The following is a description of a gene set: Reactome Pathway: Infection with Enterobacteria studied in species Homo sapiens Colonization of the gut with members of the Enterobacteriaceae family is unavoidable, as is the subsequent translocation to the urogenital tract. Infection is caused by strains with the ability to invade tissue, or when toxins are secreted. According to the WHO there are 4.5 billion cases of infection with enterobacteria every year, of which 1.9 million end in death, a number that would be much higher without antibiotics. Pneumonia and blood stream infections have the highest mortality. Gut bacteria translocate to and establish themselves in the airways by aspiration, hematogenous spread, or extension from adjacent infected structures, such as the sinuses or pleural space (W. Lee Hand & J. W. Smith, Immunology of Enterobacterial Infections; Chapter 10 in Immunology of Human Infection I, ed. A.J. Nahmias & R.J. O'Reilly, Springer Science & Business Media 2013; Hui, Leung & Padwal, Approach to Internal Medicine: A Resource Book for Clinical Practice, Edition 4, Springer 2015; Calderaro et al., 2022). As part of the environment and the gut microbiome, most members of the Enterobacteriaceae family are harmless. Pathogenic strains differ from commensals in having specific additional functions, like producing toxins and enzymes that destroy cells. They also defend themselves against the human immune system and antibiotics by the expression or overexpression of, e.g., siderophores, beta-lactamases, and fimbriae that allow them to hook onto suitable tissue and construct hard to remove biofilms. This makes enterobacteria the leading cause of diarrhea, urinary tract infection, and pneumonia, but also septicemia, peritonitis, meningitis, and device-associated infections. Through extensive exchange of genetic information on mobile elements like plasmids and the simultaneous global use of antibiotics, strains have emerged that are difficult to treat. part of: Bacterial Infection Pathways, and this is the list of marker genes: fepC, fhuC, LAMA3, UBE2D2, LAMC1, LAMB2, fecA, fes, COL4A5, secE, secG, CASP4, CALM2, papGI, LAMA2, chuA, yqjI, COL4A1, bamD, mrcB, hlyE, FN1, rrsA, EPCAM, bamB, bla, COL5A1, secY, gspC2, HBA1 (hemoglobin subunit alpha 1), acrD, tolC, gdx, znuA, LAMB3 (NCBI Gene Id 3914), mdfA, KPC-2, eltB, GBP1, lepB, exbB, skp, HBB, fimH, CALM1, fhuD, eltA, fyuA, LAMA1, dppD, sta3, COL4A2, hlyA, tetB, fecD, dppA, fecB, gyrB, bcsG, hbp, UBB, COL5A2, mdtF, gyrA, ybtP, yqjH, degP, rmtC, mdtB, LAMB1, macA, AAC(6')-Ib, COL4A3, blaSHV-12, entS, emrE, fepG, UBC, COL4A4, GBP4, mdtC, GBP6, pef, fecE, 16S rRNA, nleF, bamA, csgA, rmtG, feoA, draE, tetA, acrB, mdtE, hlyB, tonB, dppC, fepA, LAMA5, dppB, bcsB, fkpA, bcsA, bamC, gspD2, UPK1A, bcsQ, surA, sta1, feoB, mrkD, rmtH, rmtF, espC, rmtD, qnr, GBP3, znuC, sta2, dppF, bcsE, armA, fepB, znuB, macB, fecC, secA, sfaS, RPS27A, fepD, exbD, UTI89_C2180, LAMC3, ipaH9.8, efeB, COL4A6, GBP2, gspS2, efeU, yhjR, mdtA, iutA, hlyD, bamE, acrA, UBA52, oqxA, fhuB, ospC3, LAMC2, dsbA, rmtB, COL5A3, CALM3, LAMA4, efeO, mppA, bcsC